Given this list of marker genes RNU5B-1, RNU6-1, RNU5F-1, RNU5A-1, RNU4-1, RNU6-9, RNU5E-1, RNU4-2, RNU5D-1, RNU6-7, here is a description of the gene set: Human Gene Set: GOBP_FORMATION_OF_QUADRUPLE_SL_U4_U5_U6_SNRNP studied in species Homo sapiens Formation of a quadruple snRNP complex composed of the spliced leader (SL) RNA along with the U4/U6-U5 tri-snRNP complex. Interactions that may facilitate this include a duplex between the SL and U6 RNAs and interactions between the U5 RNA and the exon sequence at the 5' splice site within the SL RNA.